The following is a description of a gene set: Reactome Pathway: CLEC7A (Dectin-1) induces NFAT activation CLEC7A (Dectin-1) signals through the classic calcineurin/NFAT pathway through Syk activation phospholipase C-gamma 2 (PLCG2) leading to increased soluble IP3 (inositol trisphosphate). IP3 is able to bind endoplasmic Ca2+ channels, resulting in an influx of Ca2+ into the cytoplasm. This increase in calcium concentration induces calcineurin activation and consequently, dephosphorylation of NFAT and its translocation into the nucleus, triggering gene transcription and extracellular release of Interleukin-2. studied in species Homo sapiens part of: CLEC7A (Dectin-1) signaling, and this is the list of marker genes: PPP3CA, ITPR2, CALM1, ITPR1, NFATC3, NFATC1, AHCYL1, PPP3CB, NFATC2 (nuclear factor of activated T cells 2), ITPR3, PPP3R1